Given this list of marker genes Erbb4, Stat5a, Esr1, Psenen, Psen1, Yap1, here is a description of the gene set: studied in species Mus musculus part of: Signaling by ERBB4 Reactome Pathway: Nuclear signaling by ERBB4 This event has been computationally inferred from an event that has been demonstrated in another species.<p>The inference is based on the homology mapping from PANTHER. Briefly, reactions for which all involved PhysicalEntities (in input, output and catalyst) have a mapped orthologue/paralogue (for complexes at least 75% of components must have a mapping) are inferred to the other species. electronically inferred by orthology from the curated human pathway